The following is a description of a gene set: studied in species Homo sapiens Human Gene Set: MODULE_211 Genes in the cancer module 211., and this is the list of marker genes: AGA, MMP3, MMP2, MMP1, MMP11, PEPD, MMP9, MMP7, MMP10, CHIT1, MMP13